Given this list of marker genes Grin2c, Grin2b, Grin1, Grin2a, Grin2d, here is a description of the gene set: electronically inferred by orthology from the curated human pathway species: Mus musculus Reactome Pathway: Assembly and cell surface presentation of NMDA receptors This event has been computationally inferred from an event that has been demonstrated in another species.<p>The inference is based on the homology mapping from PANTHER. Briefly, reactions for which all involved PhysicalEntities (in input, output and catalyst) have a mapped orthologue/paralogue (for complexes at least 75% of components must have a mapping) are inferred to the other species. part of: Activation of NMDA receptors and postsynaptic events